The following is a description of a gene set: studied in species Mus musculus Mouse Gene Set: GOBP_NEGATIVE_REGULATION_OF_RECEPTOR_BINDING Any process that stops, prevents or reduces the frequency, rate or extent of a protein or other molecule binding to a receptor., and this is the list of marker genes: Rgma, Ptprf, Adam15, Il10, Pcsk9, B2m, Atp2a3, Crtac1, Hfe, Adipoq, Nog, Atp2a2